Given this list of marker genes APOBEC3B, LYN, ELF4, SCP2, TNFSF10, UBE2D3, IL15RA, SIRPB1, RTCB, ZNFX1, GSTO1, TNFRSF1B, STAT2, NAPA, LIPA, SNX10, TPM4, CD63, BLVRA, GRN, UBE2L6, TRIM34, GRB2, FBXL5, PSMB10, SPTLC2, NKG7, CREG1, ATF3, C1QA, ATOX1, CAMK2D, RNF175, ISG15, RBMS1, AIM2, KLF4, MARCKS, TLR2, CD36, ARRB1, ATP6V1B2, IFIT5, APOL3, C1QB, TRIM21, STOM, LIMK2, ZNF671 (NCBI Gene Id 79891), PEA15, DNM1, MCL1, OAS2 (2'-5'-oligoadenylate synthetase 2), MT1F, PSME2, LMO2, GBP2, PSMB2, TRIM22, ETV7, IDO1, AQP9, TNNT1, SH2B3, ICAM1, SDF2, PYHIN1, WDFY1, ANKRD22, CASP1, IRF7, SCARB2, CASP4, MICU1, EFHD2, GLRX, HERC5, FGL2 (NCBI Gene Id 10875), IFITM2, HLA-DOA, DYSF, HLA-B, SLC8A1, IL13, MX2 (MX dynamin like GTPase 2), BAZ1A, SEPTIN4, CTSL, FCGR3A, TAP1, FCGR1A, IFI44, KLHL8, SIRPA, GLS, SERPING1 (NCBI Gene Id 710), MTHFD2, DNAJC15, LILRB1, DSC2, PSMB3, BST1, OAS1, ADM, CASP5, LAP3, C2, HCK (HCK proto-oncogene, Src family tyrosine kinase), IFI44L, HLA-DQB1, LTBR, DTX3L, IL13RA1, CALCOCO2, IFIT3, TSPO, NFX1, MT1M, IRF2, LILRA3, VRK2, STAT1, SERPINA1, EIF4A1, TAF9B, MX1, SLC9A9, ACP2, CXCL9, IFI27, AP1S2, THEMIS2, NANS, ANXA5, IFI35, LGALS9, CAPG, BACH1, TNFSF13, GNG10, IFIT1, RIPK2, FPR1, RNF149, ALDH1A1, IFIT2, ALPK1, GCNT2, LHFPL2, NCF2, CTSB, LY6E, IGSF6, WARS1, EPB41L3, HLA-DRA, ACP3, GK, AIF1, PDP1, PPP1R21, PSMA6, CYBB, HLA-DPA1, IRF1, RSAD2, RHOG, TLR1, EMILIN2, IFNGR2, CTSO (cathepsin O), SOCS3, NUP62, IL15, ETF1, SORT1, PTTG1IP, PSMA4, IFI30, FCGR2B (NCBI Gene Id 2213), GCH1 (GTP cyclohydrolase 1), ALDH3B1, RAB24, CAST, ANXA2, FCN1, ST3GAL4, GNB4, TLR8, ITM2B, MYD88, LILRB3, PFKFB3, GCA (grancalcin), CYFIP1, CLSTN3, ST3GAL5, ARNT, CYFIP2, TMSB15A, CTSS, LST1, OGT, DPYD, TAP2, HLA-DRB1, JAK2, CCR1 (NCBI Gene Id 1230), KIAA0930, ADAP2, CXCL10, SLC31A2, IL1RN, TFEC, C3AR1, HP, CTNNA1, RNPEP, IFI6, FN1, LGALS3BP, NPC2, CPVL, ATF5, CES1, SRBD1, PSMB9, PSAP, CEBPB, SP110, ARPC3, TRAFD1 (NCBI Gene Id 10906), SLC43A3, LPGAT1, FUBP1, HLA-DPB1, SLC35A2, XAF1, TBX19, IFITM3, CD163, CD40, ZNF264, IRF9, PSME1, TEC, TCF7L2, NCF1, FPR2, GBP1, PLXNB2, GYG1, GLB1, BCL6, ADGRE1, MNDA, ATP1B3, IFITM1, FAS, APOL1, CASP7, GSDMD, ANXA4, TJP2, RCN1, USP18, MS4A6A, PLSCR1, PRDX2, CD74, PDXK, FKBP15, SLAMF8, S100A9, DSG2, NIBAN1, SMPDL3A, NLRP3, MARCO, CNIH4, TGOLN2, NCKAP1L, BCL2A1, DHRS9, SOD2, here is a description of the gene set: Genes up-regulated in peripheral blood mononuclear cell (5 to 7)d vs 0d in adults (18-32) after exposure to APSV Wetvax, time point 5 to 7D Human Gene Set: SCHERER_PBMC_APSV_WETVAX_AGE_18_32YO_5_TO_7DY_UP species: Homo sapiens from publication Scherer CA, Magness CL, Steiger KV, Poitinger ND, Caputo CM, Miner DG, Winokur PL, Klinzman D, McKee J, Pilar C, Ward PA, Gillham MH, Haulman NJ, Stapleton JT, Iadonato SP (PMID 17651872) Gene expression in human peripheral blood mononuclear cells was systematically evaluated following smallpox and yellow fever vaccination, and naturally occurring upper respiratory infection (URI). All three infections were characterized by the induction of many interferon stimulated genes, as well as enhanced expression of genes involved in proteolysis and antigen presentation. Vaccinia infection was also characterized by a distinct expression signature composed of up-regulation of monocyte response genes, with repression of genes expressed by B and T-cells. In contrast, the yellow fever host response was characterized by a suppression of ribosomal and translation factors, distinguishing this infection from vaccinia and URI. No significant URI-specific signature was observed, perhaps reflecting greater heterogeneity in the study population and etiological agents. Taken together, these data suggest that specific host gene expression signatures may be identified that distinguish one or a small number of virus agents.